Given this list of marker genes C12orf75, WDR54, DYNLRB2, CIMAP1B, CAPS, MS4A8, CFAP144, CFAP276, PIERCE1, TUBB4B (NCBI Gene Id 10383), CAPSL, TUBA1A, KIF9, DYNLL1, TMEM190, MRPS31, HOATZ, TEKT1, MORN5 (NCBI Gene Id 254956), IGFBP7, CIMAP3, TSPAN1, CIMIP1, ECRG4, RSPH1, CRIP1, IK, CFAP126, CIBAR2, CES1, TPPP3, DNAAF1, ZMYND10, CCDC146, DYNLT2B, PSENEN, CCDC78, CETN2, SPMIP6, CFAP53, CCDC170, FAM229B, MORN2, SNTN, EFHC1, OMG, LRRIQ1, CFAP90, AGR3, FOXJ1, here is a description of the gene set: studied in species Homo sapiens Human Gene Set: GAVISH_3CA_METAPROGRAM_EPITHELIAL_CILIA Genes upregulated in subsets of cells of a given type within various tumors from publication Gavish A, Tyler M, Greenwald AC, Hoefflin R, Simkin D, Tschernichovsky R, Galili Darnell N, Somech E, Barbolin C, Antman T, Kovarsky D, Barrett T, Gonzalez Castro LN, Halder D, Chanoch-Myers R, Laffy J, Mints M, Wider A, Tal R, Spitzer A, Hara T, Raitses-Gurevich M, Stossel C, Golan T, Tirosh A, Suvà ML, Puram SV, Tirosh I (PMID 37258682) In this study, an extensive analysis was conducted to define meta-programs (MPs) capturing intra-tumor heterogeneity across a spectrum of tumor types. The approach utilized non-negative matrix factorization (NMF) to analyze each cell type separately within individual tumor samples. This involved the analysis of malignant cells, macrophages, fibroblasts, endothelial cells, epithelial cells, T-cells, and B-cells. NMF was executed with varying parameter values (K=4, 5, 6, 7, 8, 9), thereby generating 39 programs for each cell type per sample. Each NMF program was summarized by the top genes based on NMF coefficients.\nRobust MPs were then delineated for each cell type using a set of stringent criteria, including recurrence within the same tumor, similarity to programs in other tumors, and non-redundancy within a tumor. Subsequently, these robust NMF programs were clustered (per cell type) based on Jaccard similarity, leading to the identification of MPs associated with each cell type.\nTo enhance the quality of the MPs, a refinement steps were undertaken, involving the removal of MPs suspected of reflecting low-quality data (with an overrepresentation of ribosomal proteins or mitochondrial-encoded genes), single-study inclusion, or similarity to miss-annotated cell types.